The following is a description of a gene set: Human Gene Set: HP_ABSENT_PUBIC_HAIR Absent pubic hair species: Homo sapiens Absence of pubic hair., and this is the list of marker genes: HR, GJB6, GJB2, CYP17A1, NR5A1, ITGB4, GNRH1, EPS8L3, AR